Given this list of marker genes Ccdc88a, Sirt1, Ankrd2, Appl1, Pink1, Bad, Traf6, Ppp2ca, Npm1, Bcl10, Rara, Srsf1, Cdc37, Arrb2, Srsf5, Rasa1, Pde3b, here is a description of the gene set: studied in species Mus musculus Binding to protein kinase B, an intracellular kinase that is important in regulating glucose metabolism. Mouse Gene Set: GOMF_PROTEIN_KINASE_B_BINDING